Given this list of marker genes DNAAF5, PKD1, ODAD4 (outer dynein arm docking complex subunit 4), IQCA1, DYNC2LI1, DNHD1, CIMAP1A, TCP11X1, IFT46, SPMIP8, CEP89, CUL3, RAP1A, MNS1, TUBA1A, DNAAF11, CROCC, NPHP1, TACR1, TSSK6, PMFBP1 (polyamine modulated factor 1 binding protein 1), TTLL9, ROPN1L, DNAH2, VPS13A, OFD1, PKD2, TACR3, DYNC2H1, PIERCE2, SORD, CFAP99, ADCY10 (adenylate cyclase 10), RSPH10B, CETN2, CFAP221, ENKUR, SPAG17, ABHD2, DNAI1, PACRG, SEPTIN7, HAVCR1, SPMIP11, DYDC1, TCTE1, TEKT3, TEKTL1, GK2, CCDC40, CIMIP4, ATP1A4, CATSPER1, CFAP53, RSPH3, IFT172, CTSH, CFAP52, SPAG8, RSPH4A, CFAP119, TBC1D21, DRC7, SLC22A14, DAW1, ODF2, C2CD6, EFHC2, FSCB, CIMIP2B, HYAL3, CATSPER4, RIBC2 (RIB43A domain with coiled-coils 2), CFAP126, AK2, CCDC103, TOMM20, BBOF1, ODF1, IL4I1, CIBAR1, SPA17, PGK2, CFAP68, SPATA19, CFAP44, IFT52, CFAP73, TMEM262, FLACC1, HIF1A, USP26, ODAD3, CCDC181, DRC1, SPACA9, CFAP95, IQUB, GABARAP, DNAH3, RSPH9, DDX6, DNALI1, TACR2, BBS4, SEPTIN6, GAS8, KLC3, SCNN1A (sodium channel epithelial 1 subunit alpha), DNAH10, TMEM249, PFKM, SPMIP4, FBXL13, INTU, CFAP70, CCR6, CFAP36, CFAP141, DAAM1, PIERCE1, TEKT1, ACTL7A, DRC3, CST11, CFAP43 (cilia and flagella associated protein 43), ATP1B1, LDHA, CCDC65, CATSPERZ, HVCN1, DNAH11 (NCBI Gene Id 8719), DNAI2, RSPH6A, ZMYND12, KCNU1, MORN5, LRRC46, AK7, CFAP74 (NCBI Gene Id 93196), NME8, CBY3, CFAP47, IFT81, CFAP144, CCDC146, EFCAB6, CABS1, SLC26A6, ATP1A1 (ATPase Na+/K+ transporting subunit alpha 1), CATSPERD, DRC12, CFAP45, GARIN2, SPATA6, HSPD1, BRWD1, CFAP58, TSSK3, CFAP61, SAXO1, CCDC42, SPACA3, RAN, SSNA1, SEPTIN4, HYDIN (NCBI Gene Id 84907), DNAI4, LRRC23, SPACA5B, OXCT2 (NCBI Gene Id 92407), CATSPER3, IRGC, LDHC, SPMIP5, ANXA1, HSP90AA1, TSSK4, EFHC1, RSPH1, DNAH1, CLXN (calaxin), ADAM15, SPEF1, PCDH11Y, TAS2R43, CFAP206, ATP2B4, CD52, DYNLT4, CCDC172, SPEF2, ROPN1B, DNAH7, MKKS, PAFAH1B1 (platelet activating factor acetylhydrolase 1b regulatory subunit 1), LINC02914, CAMSAP3, SLC25A31, SSX1 (SSX family member 1), TMEM232, CATSPER2, VDAC2 (NCBI Gene Id 7417), SPATA33, SPAG6, DNAJB13, IQCG, TEX55, PGAM4, TTC29, CT55, BBS2, SPMIP9, TEKT4, SPAG4, TEKT2, CEP20, IFT88, SQSTM1, CFAP210, DNAH9, RSPH10B2 (radial spoke head 10 homolog B2), DCDC2C, RNF38, DNAH17, SPATA3, MAK, DNAH8, FSIP2, EFCAB9, STARD10, IFT27, ROPN1, CCDC34, EFHB, SAXO2, PRKACA, CFAP300, IQCD, CATSPERB, CALM3, DUSP3 (NCBI Gene Id 284066), CALM2, CFAP65, CFAP91, SEPTIN12, DNAH14, LYZL6, NHERF1, CCDC38, CATSPERE, CFAP161, PTCHD3, QRICH2, NME5, C11orf42, ATP1B3, NEK5, TEKT5, GSTM3, CIMIP2A, IFT20, MROH2B, CIMAP1B, SLC9B2, RHO, SLC26A3, WDR19, AKAP3, ARL13A, SAXO4, CFAP20, CALM1, CFAP77, TEKTIP1, SLC9C1, SPAG16, WBP2NL, ARL13B, CATSPERG, CFAP90, TCP11X2, CABCOCO1, SLIRP, TTLL8, CFAP57, IFT74, TPPP2, CFAP69, KIF9, DUSP21, DNAH6, CBY1, AKAP4, TSSK1B, SEPTIN10, PPP3R2, SEPTIN2, AK9, SPMIP10, RSPH14, OAZ3, DNAH5, TTLL3, TSGA10, LYZL4 (lysozyme like 4), ATG16L1, RPGR, DRD2, RIBC1, SLC26A8 (NCBI Gene Id 65016), FHAD1 (NCBI Gene Id 114827), TCP11, AK1, BBS1, CFAP251, SPACA5, NME7, SLC9B1, TLE6, CFAP107, AK8, ACTA2, CIMIP2C, DLD, SPMIP6, CFAP100, EFCAB2, TTLL1, CABYR, TPGS1, ADGB, DEFB1, CFAP276, TUBB4B, WDR54, here is a description of the gene set: A cilium which may have a variable arrangement of axonemal microtubules and also contains molecular motors. It may beat with a whip-like pattern that promotes cell motility or transport of fluids and other cells across a cell surface, such as on epithelial cells that line the lumenal ducts of various tissues; or they may display a distinct twirling motion that directs fluid flow asymmetrically across the cellular surface to affect asymmetric body plan organization. Motile cilia can be found in single as well as multiple copies per cell. species: Homo sapiens Human Gene Set: GOCC_MOTILE_CILIUM